The following is a description of a gene set: The appearance of granulocyte macrophage colony-stimulating factor due to biosynthesis or secretion following a cellular stimulus, resulting in an increase in its intracellular or extracellular levels. studied in species Homo sapiens Human Gene Set: GOBP_GRANULOCYTE_MACROPHAGE_COLONY_STIMULATING_FACTOR_PRODUCTION, and this is the list of marker genes: IL23R, IL1B, IL18, PAEP, CD80, CARD9, TLR9, IL17D, CD84, LILRA2, IL12B, IL23A, SYK, IL17F, RIGI, ISL1